The following is a description of a gene set: Human Gene Set: GOBP_NEGATIVE_REGULATION_OF_CENTRIOLE_REPLICATION studied in species Homo sapiens Any process that stops, prevents, or reduces the frequency, rate or extent of centriole replication., and this is the list of marker genes: KAT2B, TRIM37, RBM14, KAT2A, BRCA1, CDK5RAP2, MDM1